Given this list of marker genes STIMATE, STIM1, STIM2, CRACR2A, ASPH, here is a description of the gene set: Human Gene Set: GOBP_ACTIVATION_OF_STORE_OPERATED_CALCIUM_CHANNEL_ACTIVITY A process that initiates the activity of an inactive store-operated calcium channel. species: Homo sapiens